Given this list of marker genes TWNK, MPV17, PARP1, TP53, ENDOG, POLG2, RRM2B, PRIMPOL (primase and DNA directed polymerase), STOX1, NEURL4, RRM1, LONP1, METTL4, POLG, SESN2, LIG3, TEFM, DNA2, DNAJA3, SSBP1, MGME1, TOP3A, POLRMT, here is a description of the gene set: species: Homo sapiens Human Gene Set: GOBP_MITOCHONDRIAL_DNA_METABOLIC_PROCESS The chemical reactions and pathways involving mitochondrial DNA.